Given this list of marker genes Sdc1, Stam (NCBI Gene Id 20844), Rab7, Cd34, Pdcd6ip, Arrdc4, Atp9a, Chmp2a, Prkn, Vps4b (NCBI Gene Id 319619), Sdc4, Cops5, Vps4a, Hgs, Myo5b, Steap3, Arrdc1, Atp13a2, Rab11a, Snf8, Tsg101, Smpd3, Sdcbp (NCBI Gene Id 53378), Rab27a (RAB27A, member RAS oncogene family), here is a description of the gene set: The assembly and secretion a set of components to form an extracellular vesicule, a membrane-bounded vesicle that is released into the extracellular region. Extracellular vesicles include exosomes, microvesicles and apoptotic bodies, based on the mechanism by which they are released from cells and differentiated based on their size and content. Mouse Gene Set: GOBP_EXTRACELLULAR_VESICLE_BIOGENESIS species: Mus musculus